The following is a description of a gene set: Any mRNA 3'-end processing that involves the binding to and cleavage of a stem-loop structure. For example, histone mRNAs contain a highly conserved stem-loop sequence at the 3' end of the mRNA with a 6 base pairs (bp) stem and a 4-nt loop. The mRNA is cleaved between these two elements, after the fourth or fifth nucleotide, which is typically an adenosine. Human Gene Set: GOBP_MRNA_3_END_PROCESSING_BY_STEM_LOOP_BINDING_AND_CLEAVAGE species: Homo sapiens, and this is the list of marker genes: CPSF2, CPSF3, LSM11, LSM10, ZNF473, SLBP